Given this list of marker genes PTH2R, ACKR1, GRASLND, RHAG, PIGQ, GYPA, TRAK2 (trafficking kinesin protein 2), ASIC4, ANK1, DNAJC6-AS1, UBAC1, LINC02444, HBBP1, ABCB10, EIF5AP2, SPTB (spectrin beta, erythrocytic), RNU6-87P, ABCC13, TRIM10, SLC6A9, GYPB, ENSG00000261697, ABCB5, SEC14L3, ADAM7, ALAS2, SLC25A37, SLC4A1, EPB42, KRT13, MINPP1, ENSG00000260592, ANKRD61, OSBP2, ERFE, A4GALT, SLC22A4, SLC38A5, KLF1, RHD, CPOX, C17orf99, KEL, PPT2, RHCE, ALAD, RNU6-1057P, ACHE, DNAJA4, ERVE-1, TMOD1 (tropomodulin 1), RPS12P7, RFESD, SLC5A4-AS1, SPTA1, SLC25A21, HDC, SEC14L4, LINC01399, SHISA7, TFRC, CD46P1, ART4, ACSBG1, RNU6-670P, TDH, GYPE (glycophorin E (MNS blood group), NCBI Gene Id 82246), ENSG00000226281, UROS, FKBPL, KCNH2, XG, SPMAP2L, FLACC1, EPOR, ODAD4, TSPAN17, FHDC1, ADD2, SLC14A1, here is a description of the gene set: species: Homo sapiens Marker genes curated from the annotated cluster as represented in the Descartes Human Gene Expression During Development database. The gene expression program underlying the specification of human cell types is of fundamental interest. The study authors generated human cell atlases of gene expression and chromatin accessibility in fetal tissues. For gene expression, the study authors applied three-level combinatorial indexing to >110 samples representing 15 organs, ultimately profiling ~4 million single cells. The study authors leveraged the literature and other atlases to identify and annotate hundreds of cell types and subtypes, both within and across tissues. Our analyses focused on organ-specific specializations of broadly distributed cell types (such as blood, endothelial, and epithelial), sites of fetal erythropoiesis (which notably included the adrenal gland), and integration with mouse developmental atlases (such as conserved specification of blood cells). These data represent a rich resource for the exploration of in vivo human gene expression in diverse tissues and cell types. Human Gene Set: DESCARTES_FETAL_LIVER_ERYTHROBLASTS from publication Cao J, O'Day DR, Pliner HA, Kingsley PD, Deng M, Daza RM, Zager MA, Aldinger KA, Blecher-Gonen R, Zhang F, Spielmann M, Palis J, Doherty D, Steemers FJ, Glass IA, Trapnell C, Shendure J (PMID 33184181)